Given this list of marker genes CD8A, CD81, TUBB4B, VCP, ATP5F1A, TRAV8-4, LILRB2, TAP2, KLRD1, CD8B, KIR2DS4, COL2A1, TRBV7-9, TUBB, KLRK1, TRGV3, CD4, PILRA, CD8B2, BCAP31, CLEC7A, LAG3, TRAV29DV5, PILRB, ATP5F1B, MARCHF1, TRBV12-3 (NCBI Gene Id 28577), KIR3DL2, TAPBP, CD244, TRAV19, TRGV9, CD74, CYRIB, KLRC4-KLRK1, DERL1, FCRL6, HLA-E, MARCHF8, LILRB1, TAP1, here is a description of the gene set: Binding to a major histocompatibility complex molecule; a set of molecules displayed on cell surfaces that are responsible for lymphocyte recognition and antigen presentation. studied in species Homo sapiens Human Gene Set: GOMF_MHC_PROTEIN_BINDING